Given this list of marker genes Fgf16, Fgf20, Fgf2, Fgf6, Fgf17, Fgf23, Fgf15, Klb, Fgf4, Fgf1, Fgf8, here is a description of the gene set: studied in species Mus musculus part of: Downstream signaling of activated FGFR4 electronically inferred by orthology from the curated human pathway This event has been computationally inferred from an event that has been demonstrated in another species.<p>The inference is based on the homology mapping from PANTHER. Briefly, reactions for which all involved PhysicalEntities (in input, output and catalyst) have a mapped orthologue/paralogue (for complexes at least 75% of components must have a mapping) are inferred to the other species. Reactome Pathway: Phospholipase C-mediated cascade; FGFR4